The following is a description of a gene set: species: Homo sapiens Human Gene Set: HP_SMALL_PLACENTA Small placenta Reduced size of the placenta., and this is the list of marker genes: ZMPSTE24, PHGDH, LMNA, HMGA2, MUSK, IGF1, CDKN1C, IGF2, PLAG1